Given this list of marker genes AQP8, CELP, PRSS3, PRSS3P2, SERPINI2, CTRL, SPINK1, CELA3B, PNLIP, CELA2B, CELA2A, PNLIPRP2, CLPS, CELA3A, CTRB1, CPA2, PDIA2, PLA2G1B, PRSS1, CPA1, CPB1, PNLIPRP1, CEL, PRSS2, CTRC, here is a description of the gene set: Neighborhood of SERPINI2 serpin peptidase inhibitor, clade I (pancpin), member 2 in the GNF2 expression compendium Neighborhood of SERPINI2 Human Gene Set: GNF2_SERPINI2 studied in species Homo sapiens